The following is a description of a gene set: Mouse Gene Set: GOBP_REGULATED_EXOCYTOSIS A process of exocytosis in which soluble proteins and other substances are initially stored in secretory vesicles for later release. It is found mainly in cells that are specialized for secreting products such as hormones, neurotransmitters, or digestive enzymes rapidly on demand. studied in species Mus musculus, and this is the list of marker genes: Lrrk2, Cd300a, Rimbp2, Lyn, Rab44, Cacna1a, Bcl2l1, Syt15, Scamp5, Otof, Ccr2, Spi1, Baiap3, Ppfia2, Orai1, Vamp1, Mrgprb1, Cacna1i, Arf1, Sphk2, Cd177, Fcgr4, Napb, Cacna1e, Rest, Syngr1, Prkaca, Ptgds, Rap1a, Lat2, Syn1, Efr3a, Kcnh1, Pla2g3, Rab27a, Vps41, Syngr3, Nlgn1, Gata1, Stxbp1 (NCBI Gene Id 98927), Dvl1, D6Wsu163e, Ccl3, Anxa3, Cd160, Ceacam1, Rapgef4, Scn11a, Pi4k2a, Stxbp5l, Syt17, Sdf4, Rph3al, Crhr1, Septin5, Syt5, Rims4, Fbxo45, Synj1, Tmed10, Dnm1l, Syt3, Syde1, Fes, Pikfyve, Gpr15lg, Lamp1, P2ry2, Arl8b, Pfn2, Ppfia3, Steap2, Clnk, Sptbn2, Nlrp5, Syt1, Syt9, Git2, Ppp3cb, Kit, Vamp2, Syt7, Btk, Il13, Snap47, Stxbp2, Unc13a, Cacna1h, Rab11fip2, Milr1, Osbpl2, Crhbp, Lgals9, F2rl1, Sv2c, Nppc, Snx4, Wnt7a, Cacna1b, Cacnb4, Itgb2l, Snapin, Fgr, Abca12, Il4ra, Prkca, Trim9, Zp3, Syt11, Psen1, Cacna1d, Htr1d, Nr4a3 (NCBI Gene Id 18124), Pram1, Rab5a, Vamp8, Rab11fip5, Tspan18, Grik5, Rims2, Syt12, Doc2g, Braf, Cspg5, P2rx2, Rasgrp1, Adora2b, Rab3gap1, Notch1, Mical1, Prkcg, Rab11fip1, Doc2b, Syt2, Kctd9, Lat, Gata2, Abr, Unc13d, Itgam, Cplx1, Atp2a2, Fcer1a, Cplx2, Cacna1g, Eqtn, Brsk1, Pdpk1, Scrib, Kcnb1, Rims3, Hmox1, Pclo, Cadps2, Napa, Stxbp3, Cdk5, Syk, Syt6, P2rx1 (NCBI Gene Id 18568), Snca, Erc1, Ywhaz, Rab15, Rph3a, Cask, Nkg7, Mrgprx2, Grp, Rab3a, Tprg1l, Ap1g1, Syt13 (synaptotagmin XIII), Ptgdr, Rab11b, Lypd11, Foxf1, Stxbp5, Bcr, Rab3d (NCBI Gene Id 83761), Gab2, Slc4a8, Syt10, Syt4, Camk2a, Il13ra2, Snap23, Hyal3, Tmem79, Stx1b, Snap25, Ncs1, Prepl, Ptafr, Rab10, Fmr1, Rap1b, Rab31, Vps18 (NCBI Gene Id 228545), Stx2, Syn2, P2ry1, Erc2, Syt8, Sv2b, Cplx4, Il4, Cbarp, Rab26, Stx11, Syngr2, Npy, Unc13b, Npy1r, Pex5l, Vamp3, Cd84, Gnai2, Stx1a, Fcer1g, Chga, Pld2, Coro1a, Adra2a, Snap29, Syp, Cltrn, Rabgef1, P2rx7, Gpr151, Stx4a, Cacna1c (NCBI Gene Id 619317), Prkcb, Adora3, Lypd10, Slc18a2, Ctbp2, Sv2a, Cdk5r2, Itgb2, Cbl, Cplx3, Cadps, Unc13c, Dtnbp1, Tph1, Prrt2, Rac2, Arhgap17, Fbxl20, Plek, Pou5f1, P2ry4, Ighe, Nppa, Git1, Rims1, Myh9, Myo1f, Stx19, Ms4a2, Nckap1l, Tac4, Doc2a, Htr1b